Given this list of marker genes SLC25A42, LRRC8E, LBP, VLDLR, RFT1, SLC25A41, SLC29A1, SLC35B1, PLTP, ABCC6, SLC35A1, G6PC1, SLC35C2, SLC35B4, LRRC8D, SLC5A2, LRRC8B (leucine rich repeat containing 8 VRAC subunit B), SLC35C1 (solute carrier family 35 member C1), SLC37A3, CPTP, SLC46A2, CD47, CALHM4, SLC25A19, GLTP, GUK1, SLC37A4, SLC17A3 (solute carrier family 17 member 3), SPNS1, SLC25A4 (solute carrier family 25 member 4), SLC28A1, NPC2, PANX1, ABCC4, CALHM5, ABCC3, MFSD2A, SLC25A17, SLC29A2, SLC28A2, SLC28A3, TMEM241, SLC25A24, G6PC3, SLC35A4, SCARB1, SLC37A2, SLC15A3, SLC37A1, SLC35D3, SHOC2, PSAP, ADORA1, ABCB1, SLC25A31, SLC35A5, SLC29A4 (solute carrier family 29 member 4), SLC25A5, CALHM3, SLC25A26, CALHM6, CR1, CALHM1, SLC15A2, SLC35E3, SLC15A4, SLC25A25, CALHM2, SLC35A3, SLC17A9, ANKH, PLEKHA8, LRRC8A, LRRC8C, RALBP1, RSC1A1, SLC35A2, SLC29A3, PLA2G10, ADCY10, SLC35D1, ABCC5, CLN3, SLC5A1, SLC25A23, SLC19A1, SLC35B2, SLC25A6, SLC35D2, SLC35B3, SLC50A1, ABCG1, here is a description of the gene set: studied in species Homo sapiens The directed movement of a carbohydrate derivative into, out of or within a cell, or between cells, by means of some agent such as a transporter or pore. Human Gene Set: GOBP_CARBOHYDRATE_DERIVATIVE_TRANSPORT